Given this list of marker genes NKX6-1, SLC2A5, SYT13, SRP9, IAPP, RIMS3, FOXJ1, PSMB10, PPP1R1A, PPY, NEUROD1, FRZB, VDR, PAX4, SLC2A2, G6PC2, INS, RBP4, NEUROG3, SST, ISL1, CHGA, LDLR, GCG, GHRL, GJD2, SYTL4, MAFB, SCG5, CTRL, PCSK2, CLTRN, PAX6, ABCC8, PYY, SCGN, here is a description of the gene set: Human Gene Set: KANG_GLIS3_TARGETS species: Mus musculus Genes downregulated in the postnatal day 3 pancreata with impaired function of GLIS3. Chromatin assembly factor 1 (CAF-1) deposits histones H3 and H4 rapidly behind replication forks through an interaction with the proliferating cell nuclear antigen (PCNA), a DNA polymerase processivity factor that also binds to a number of replication enzymes and other proteins that act on nascent DNA. The mechanisms that enable CAF-1 and other PCNA-binding proteins to function harmoniously at the replication fork are poorly understood. Here we report that the large subunit of human CAF-1 (p150) contains two distinct PCNA interaction peptides (PIPs). The N-terminal PIP binds strongly to PCNA in vitro but, surprisingly, is dispensable for nucleosome assembly and only makes a modest contribution to targeting p150 to DNA replication foci in vivo. In contrast, the internal PIP (PIP2) lacks one of the highly conserved residues of canonical PIPs and binds weakly to PCNA. Surprisingly, PIP2 is essential for nucleosome assembly during DNA replication in vitro and plays a major role in targeting p150 to sites of DNA replication. Unlike canonical PIPs, such as that of p21, the two p150 PIPs are capable of preferentially inhibiting nucleosome assembly, rather than DNA synthesis, suggesting that intrinsic features of these peptides are part of the mechanism that enables CAF-1 to function behind replication forks without interfering with other PCNA-mediated processes. from publication Kang HS, Kim YS, ZeRuth G, Beak JY, Gerrish K, Kilic G, Sosa-Pineda B, Jensen J, Pierreux CE, Lemaigre FP, Foley J, Jetten AM (PMID 19805515)